Given this list of marker genes SFRP1, CADM4, SAMSN1, VPS25, SNX6 (NCBI Gene Id 58533), DMTN, ZFYVE28, GPRC5A, PTK6 (NCBI Gene Id 5753, protein tyrosine kinase 6), PARP14, SFRP2, SRCIN1, ZGPAT, INPP5F, PTPN2, SOCS4, CHMP6, TSG101, PIBF1, SOCS5, ERRFI1, MVP, here is a description of the gene set: Human Gene Set: GOBP_NEGATIVE_REGULATION_OF_PEPTIDYL_TYROSINE_PHOSPHORYLATION Any process that stops, prevents, or reduces the frequency, rate or extent of the phosphorylation of peptidyl-tyrosine. studied in species Homo sapiens